Given this list of marker genes Dll1, Nkx2-2, Cftr, Mir214, Mir541, Gdf11, Insm1, Mir503, Bmp6, Bmp4, Nkx6-1, Mir375 (microRNA 375), Clock, Pdpk1, Cdk6, Sidt2, Bmp5, Bhlha15, Bad, Cdh2, Wnt5a, Smo, Rheb, Bmal1, Rfx3, here is a description of the gene set: The process whose specific outcome is the progression of a type B pancreatic cell over time, from its formation to the mature structure. A type B pancreatic cell is a cell located towards center of the islets of Langerhans that secretes insulin. studied in species Mus musculus Mouse Gene Set: GOBP_TYPE_B_PANCREATIC_CELL_DEVELOPMENT